Given this list of marker genes Fxyd3, Pxn, Kcnj14, Tmod2, Atp2b3, Tln1, Gucy1b2, Calm1, Tnnt3, Tmod3, Tmod4, Pln, Atp1a2, Kcne5, Tmod1, Ces1d, Vim, Atp1b1, Trpc1, Myl9, Tcap, Atp1a3, Casq1, Tpm3, Myl3, Kcnj12, Corin, Kcnk4, Atp2a1, Atp2b4, Cacng7, Nppc, Myh3, Atp2b1, Kcnk3, Myl7, Cacnb1, Kcnh2, Dmpk, Kcnk12, Actc1, Kcnk16, Trdn, Gucy1b1, Itgb5, Kcnk18, Tnni2, Kcnj2, Camk2b, Kcnk6, Tnnc1, Npr2, Myl2, Actn3, Myl1, Myl6, Kcnk5, Kcnj11, Kcnip4, Actg2, Ryr1, Fkbp1b, Kcnip2, Cacna2d2, Tnnt1, Stim1, Cacng4, Tnnc2, Tnni3, Atp1b2, Fxyd2, Acta1, Nppa, Pde5a, Des, Atp1b3, Mybpc2, Prkaca, Tpm2, Tnnt2 (NCBI Gene Id 21956), Lmod1, Atp2a3, here is a description of the gene set: species: Mus musculus electronically inferred by orthology from the curated human pathway Reactome Pathway: Muscle contraction This event has been computationally inferred from an event that has been demonstrated in another species.<p>The inference is based on the homology mapping from PANTHER. Briefly, reactions for which all involved PhysicalEntities (in input, output and catalyst) have a mapped orthologue/paralogue (for complexes at least 75% of components must have a mapping) are inferred to the other species.